Given this list of marker genes ZBTB18, TTC9, LPIN1, TMCC1, TCEAL1, MME, SLC22A11 (NCBI Gene Id 55867), CBR1 (NCBI Gene Id 873), HEXA, ASPSCR1, ATP6V0E2, FBXL5, BMP4, LEF1, NPR2, HSDL2, TIMM17A, EFR3A (NCBI Gene Id 23167), BPNT2, AP3S1, RNF43, ITPR2, DYNC1I1, SLC5A6, SLC13A3, VSNL1 (visinin like 1), TBCA, COL7A1, ACTN2, SEPTIN4, REG1A, RAB4A, ACSS3, BCAP31, CEMIP2 (NCBI Gene Id 23670), SIAH2, FIRRM, C1QTNF3, SLC6A2, CTNNA2, PANX1 (NCBI Gene Id 24145), TRIB2, ACSL6, PARVB, CCDC170, GALNT1, GGH, MERTK, CRYZ, NEK3, SAMM50, YPEL1, MLEC, CTNNBL1, LGALS8, UGGT1, VSTM4, SULT4A1, THSD1, GREB1, PREB, SLC22A4, MARCHF8, RHOBTB1, WASHC3, FHIT (NCBI Gene Id 2385), here is a description of the gene set: Human Gene Set: BOYAULT_LIVER_CANCER_SUBCLASS_G6_UP Hepatocellular carcinomas (HCCs) are a heterogeneous group of tumors that differ in risk factors and genetic alterations. We further investigated transcriptome-genotype-phenotype correlations in HCC. Global transcriptome analyses were performed on 57 HCCs and 3 hepatocellular adenomas and validated by quantitative RT-PCR using 63 additional HCCs. We determined loss of heterozygosity, gene mutations, promoter methylation of CDH1 and CDKN2A, and HBV DNA copy number for each tumor. Unsupervised transcriptome analysis identified 6 robust subgroups of HCC (G1-G6) associated with clinical and genetic characteristics. G1 tumors were associated with low copy number of HBV and overexpression of genes expressed in fetal liver and controlled by parental imprinting. G2 included HCCs infected with a high copy number of HBV and mutations in PIK3CA and TP53. In these first groups, we detected specific activation of the AKT pathway. G3 tumors were typified by mutation of TP53 and overexpression of genes controlling the cell cycle. G4 was a heterogeneous subgroup of tumors including TCF1-mutated hepatocellular adenomas and carcinomas. G5 and G6 were strongly related to beta-catenin mutations that lead to Wnt pathway activation; in particular, G6 tumors were characterized by satellite nodules, higher activation of the Wnt pathway, and E-cadherin underexpression. CONCLUSION: These results have furthered our understanding of the genetic diversity of human HCC and have provided specific identifiers for classifying tumors. In addition, our classification has potential therapeutic implications because 50% of the tumors were related to WNT or AKT pathway activation, which potentially could be targeted by specific inhibiting therapies. Up-regulated genes in hepatocellular carcinoma (HCC) subclass G6, defined by unsupervised clustering. from publication Boyault S, Rickman DS, de Reyniès A, Balabaud C, Rebouissou S, Jeannot E, Hérault A, Saric J, Belghiti J, Franco D, Bioulac-Sage P, Laurent-Puig P, Zucman-Rossi J (PMID 17187432) studied in species Homo sapiens